Given this list of marker genes SEPTIN6, SYT14, NRG1, B4GALT6, HGF, ANK2, GUCY1A1, SESN3, NUP62CL, AHNAK2, XK, PLK2, PAPPA, S100A2, OSBPL6, CPVL, RAB31, MAP2, CD163L1, TSPAN18, RAB3C, DRAM1, SERPINE1, NACC2, ATXN1, EEF1A2, MAML2, RETREG1, GAD1, HHIP, PLS3, HSPB8, PCDH17, ACAD11, PXDN, FAM30A, TMEM74, GLS, HBE1, NRIP1, STXBP5, SOX6, TENT5A, SEL1L3, FSTL5, PHLDA2, TNIK (TRAF2 and NCK interacting kinase), PAG1, FAS, LGALS3, UPP1, LURAP1L, ARHGAP36, MOSPD1, RGS13, SCN9A, RELN, DCLK1, RPS6KA3, STAMBPL1, DGKK, ITGA2, FAM199X, IFI16, ODAM, SCG2, NRXN1, DUSP4, IGSF1, PDGFA, HS2ST1, NAP1L1, ENDOD1, IGHM, GAP43, STEAP3, CLCN5, GSAP, EPS8, ARHGAP26, MET, DEPTOR, FAM131B-AS2, GRIK2, RND3, MGAT4C, TRIM44, ACVRL1, SLC27A6, NTS, SLC41A2, PRSS12, PDLIM5, TRAF3IP2, PCDH7, CCNB3, S100A10, LINC00511, STK17B (NCBI Gene Id 9262), FAM89A, NXT2, ZDHHC2, HS6ST3, CLSTN2, HS3ST3B1, KISS1R, FAM114A1, ADGRG2, SPARCL1, HS3ST3A1, H19, PDZK1, RGS16, CEBPB, SPATS2L, PLEKHA5, CYB561, GDF15, CPEB1, HEY1, INSYN2B, ERGIC2, THSD4, CAPN6, NRCAM, HSPA4L, KCNH8, SMKR1 (NCBI Gene Id 100291710), TRNP1, RBM24, GPR22 (NCBI Gene Id 2845), DCBLD2, PHACTR2, CHRM3, OSBPL3, NAV1, SLC18A1, LIMS1, GNAS, EDN3, UTS2, here is a description of the gene set: Genes up-regulated in SH-SY5Y cells (neuroblastoma) after knockdown of NF1 by RNAi. species: Homo sapiens from publication Hölzel M, Huang S, Koster J, Ora I, Lakeman A, Caron H, Nijkamp W, Xie J, Callens T, Asgharzadeh S, Seeger RC, Messiaen L, Versteeg R, Bernards R (PMID 20655465) Retinoic acid (RA) induces differentiation of neuroblastoma cells in vitro and is used with variable success to treat aggressive forms of this disease. This variability in clinical response to RA is enigmatic, as no mutations in components of the RA signaling cascade have been found. Using a large-scale RNAi genetic screen, we identify crosstalk between the tumor suppressor NF1 and retinoic acid-induced differentiation in neuroblastoma. Loss of NF1 activates RAS-MEK signaling, which in turn represses ZNF423, a critical transcriptional coactivator of the retinoic acid receptors. Neuroblastomas with low levels of both NF1 and ZNF423 have extremely poor outcome. We find NF1 mutations in neuroblastoma cell lines and in primary tumors. Inhibition of MEK signaling downstream of NF1 restores responsiveness to RA, suggesting a therapeutic strategy to overcome RA resistance in NF1-deficient neuroblastomas. Human Gene Set: HOELZEL_NF1_TARGETS_UP